Given this list of marker genes CAMK4, SIN3A, MECP2, HDAC3, TBL1XR1, HDAC1, NCOR2, BDNF, GPS2, PRKACA, CALM1, TBL1X (NCBI Gene Id 6907), NCOR1, here is a description of the gene set: Reactome Pathway: Loss of function of MECP2 in Rett syndrome studied in species Homo sapiens part of: Pervasive developmental disorders Loss of function mutations in methyl-CpG-binding protein 2 (MECP2), an epigenetic regulator of transcription, are the major cause of Rett syndrome, a neurodevelopmental disorder that affects 1 in 10,000-15,000 female births. The symptoms of Rett syndrome appear after 6-18 months of apparently normal postnatal development and include regression of acquired language and motor skills, stereotypic hand movements, intellectual disability, epileptic seizures and respiratory disturbances. Besides Rett syndrome, aberrant MECP2 expression is implicated as an underlying cause of other neuropsychiatric disorders. Only functionally characterized MECP2 mutations are annotated. For a comprehensive list of MECP2 mutations reported in Rett syndrome, please refer to the RettBASE (http://mecp2.chw.edu.au), a database dedicated to curation of disease variants of MECP2, CDKL5 and FOXG1 in Rett syndrome.<br><br>The pathway "Loss of MECP2 binding ability to the NCoR/SMRT complex" describes MECP2 loss-of-function mutations reported in Rett syndrome that impair its ability to associate with the NCoR/SMRT complex.<br><br>The pathway "Loss of phosphorylation of MECP2 at T308" describe loss-of-function mutations in MECP2 reported in Rett syndrome that impair its ability to undergo phosphorylation at threonine residue 308 in response to neuronal activity.<br><br>The pathway "Loss of MECP2 binding ability to 5hmC-DNA" describes MECP2 loss-of-function mutations reported in Rett syndrome that impair the ability of MECP2 to bind to hydroxymethylated DNA.<br><br>The pathway "Loss of MECP2 binding ability to 5mC-DNA" describes MECP2 loss-of-function mutations reported in Rett syndrome that impair the ability of MECP2 to bind to methylated DNA.